Given this list of marker genes Mir452 (microRNA 452), Folr1, Bmp4, Cdc42, Bmp7, Jag1, Ednra, Twist1, Pitx2, Hes1, Dicer1, Eng, Mapk3, Ankrd11, Edn1, Sema3c, Mapk1, Hand2, Lrp6, Cited2, Nrp1, here is a description of the gene set: Mouse Gene Set: GOBP_CARDIAC_NEURAL_CREST_CELL_DIFFERENTIATION_INVOLVED_IN_HEART_DEVELOPMENT studied in species Mus musculus The process in which a relatively unspecialized cell acquires specialized features of a cardiac neural crest cell that will migrate to the heart and contribute to its development. Cardiac neural crest cells are specialized cells that migrate toward the heart from the third, fourth and sixth pharyngeal arches.